The following is a description of a gene set: The chemical reactions and pathways involving a polyol, any alcohol containing three or more hydroxyl groups attached to saturated carbon atoms. species: Homo sapiens Human Gene Set: GOBP_POLYOL_METABOLIC_PROCESS, and this is the list of marker genes: GPER1, PGP, PRKG1, NTSR1, ASAH1, GALR2, ACER2, CD244, ITPKB, IPPK, PTAFR, NUDT3, SPTLC1, PPIP5K1, PTH, NAAA, OCRL, PTS, DHFRP1, COQ2, MOGAT1, SPTLC3, PLEK (pleckstrin), ANGPTL3 (angiopoietin like 3), LHCGR, INPP4B, SPTSSA, ISYNA1, INPP5A, DGAT2, GK, ITPKC, PCBD2, NUDT10, TKFC, ABCA2, PCBD1, INPP5J, DHFR, ACER1, PCK2, IP6K3, SPTSSB, TPI1, LEP, MIOX, COQ3, SPHK1, IP6K1, CYP24A1, P2RY6, LRP2, GK5, SLC5A3, GALK1, ITPKA, SPHK2, CYP27A1, CYP2R1, INPP5B, PLCB1, NUDT4, GOT1, IP6K2, CYP3A4, GPD2, SPR, ACER3, FKRP, PCK1, IPMK, GK2, SGPP2, SLC34A1, AVPR1B, PRKG2, NOS3, NUDT4B, PLPP1, PLPP3, IMPA2, SORD, MINPP1, SGPP1, SNCA, ITPK1, GBA1, SPTLC2, AGK, SYNJ1, PLCG2, MECP2, ASAH2, MOGAT3, INPP4A, ADCYAP1R1, PLA2G4A, IMPA1, DEGS2, QDPR, P2RY1, MOGAT2, NUDT11, CYP27B1, SCP2, GCH1, PPIP5K2, PLPP2, PTH1R